The following is a description of a gene set: studied in species Homo sapiens Catalysis of the reaction: a nucleoside diphosphate + H2O = a nucleoside monophosphate + phosphate. Human Gene Set: GOMF_NUCLEOSIDE_DIPHOSPHATE_PHOSPHATASE_ACTIVITY, and this is the list of marker genes: ENTPD5, NUDT18, NUDT16, NUDT15, ENTPD3, ENTPD6, PGP, NUDT5, SLC25A42, GBP1, CANT1, ALPL, ENTPD8, ENTPD4, ENTPD7, ENTPD1, ENTPD2